Given this list of marker genes mt-Co2, Slc25a14, Atp5mg, Atp6v0d1, Tmem175, Slc45a1, Slc45a3, Ucp3, Atp5mc3, Ucp1, mt-Nd3, Chp1, Hvcn1, Atp6v1e2 (NCBI Gene Id 74915), Slc2a13, mt-Nd4, Atp6v0e, Slc47a1, Atp5f1b, Slc9a4, Otop1, Slc9c1, Asic5, Slc38a3, Slc38a5, Atp4b, Slc11a2 (NCBI Gene Id 18174), Tmco3, Slc9a8, Atp5f1d, Ndufs1, Slc25a4 (NCBI Gene Id 11739), Atp6v1h, Atp6v0e2, Slc30a5, Cox7a1, Ndufv2, Ndufs2, Atp5f1a, mt-Nd1, Atp6v0c, mt-Co1, Atp6v1c1, Slc9a6 (solute carrier family 9 (sodium/hydrogen exchanger), member 6), Atp5mf, Slc9a1, Slc18a1, Otop2, Atp6v0d2, Atp6v0b, Atp6v0a4, Slc16a1, Atp5f1c, Ndufv1 (NCBI Gene Id 225885), Atp6v1a, Slc18a3, mt-Co3, Uqcrfs1, Otop3, Slc25a5, Slc30a1, Ndufa2 (NCBI Gene Id 17991), Atp6v1g3, Slc25a12, Slc18b1, Slc9a7, Ndufs7, Atp6v0a2, Slc30a8, mt-Atp6, Slc25a13, Letm1, Atp12a, Slc9b2, Ucp2, Atp6v1c2, Ctns, Slc25a3, Slc17a7, Slc46a1, mt-Nd5, Atp6v1g2, Slc36a1, Cyc1, Atp5pf, Atp5f1e, Slc32a1, Slc25a18 (solute carrier family 25 (mitochondrial carrier), member 18), Atp6v1f, Slc9a5, mt-Atp8 (mitochondrially encoded ATP synthase 8), Cox4i2, Ghitm, Ndufs4, Cybb, Surf1, Cox5a, Atp6v0a1, mt-Nd4l, Slc25a27, Atp5me, Atp5mc2, Sting1, Atp5pb, Slc17a6, Atp5pd, Ndufa10, Slc5a4a, Atp6v1d, Uqcrh, Atp6v1b1, Slc9a2, Slc36a3, Ndufs3, Slc11a1, Slc15a1, Slc2a4, Slc45a4, Slc25a22, mt-Nd2, mt-Nd6, Nnt, Ndufs8 (NCBI Gene Id 225887), Atp6v1b2, Atp5mc1, Slc9a3, Slc18a2, Atp6-ps, mt-Cytb, Atp5po, Uqcrh-ps1, Atp6v1e1, Slc16a3, Slc36a2, Clcn3, Slc4a11, Atp4a, Slc15a4, Atp6v1g1, Ndufb7, Slc47a2, Slc9a9, Slc45a2, Slc15a2, Atg5lrt, Clcn7, Slc30a2, here is a description of the gene set: species: Mus musculus Enables the transfer of a proton from one side of a membrane to the other. Mouse Gene Set: GOMF_PROTON_TRANSMEMBRANE_TRANSPORTER_ACTIVITY